The following is a description of a gene set: The process in which the anatomical structures of epithelia are generated and organized. An epithelium consists of closely packed cells arranged in one or more layers, that covers the outer surfaces of the body or lines any internal cavity or tube. species: Mus musculus Mouse Gene Set: GOBP_MORPHOGENESIS_OF_AN_EPITHELIUM, and this is the list of marker genes: Etv5, Astn2, Celsr1, Vegfc, Lef1, Fgf7, Setdb2 (NCBI Gene Id 239122), Cobl, Fgfr3, Foxn1, Acvrl1, Podxl, Flna, Clic4, Tfap2a, Stat5a, Brpf1, Nkd1, Smad4, Lin7c, Gli3, Dlg1, Bcl2, Mir216b, Ripk4, Dlg3, Adamts12, Sox11, Dlc1, Rarg, Epha2, Dll1, Fat1, Maged1 (MAGE family member D1), Eng, Rnf207, Foxa1, Bcl10, Grem1, Fermt2, Erbb4, Hey1, Wdpcp, Bbs4, Wnt2, Cc2d2a (coiled-coil and C2 domain containing 2A), Pax2, Nrarp (NCBI Gene Id 67122), Phldb2, Htt, Irx1, Rxra, Ccn1, Pard3, Brsk2, Fzd3, Pla2g10, Krt6a, Hoxb7, Plxna1, Hs3st3b1, Nfatc4, Rspo2, BC028528, Aldh1a3, Gsdma3, Casr, Igf1, Lbx2, Prkaca, Alx1, Hand2, Tgm2, Ahi1, Arl13b, Timeless, Tcf21, Fermt1, Mmrn2, Cxcl12, Cluap1, Specc1l, Dll4 (NCBI Gene Id 54485), Etv4, Robo1, Wnk4, Krt71, Kras, Cd44, Tbx18, Wnt9b, Pak1, Smarca1 (SWI/SNF related, matrix associated, actin dependent regulator of chromatin, subfamily a, member 1), Cited1, Scnn1g, Tgfb2, Ovol2 (NCBI Gene Id 69059), Wnt3a, Col5a1, Lhx2, Brsk1, Pthlh (parathyroid hormone-like peptide, NCBI Gene Id 19227), Prkacb, Rhoc, Lif, Itgax, Vegfa (NCBI Gene Id 22339), Apaf1, Epha7, Tacstd2, Wt1, Sulf1, Ppp1ca, Ilk, Cdh1, Camsap3, Spint1, Alox12, Clasp1, Sox9, Runx3, Fat4, Commd5, Cd151, Zic2, Fzd5, Hoxa13, Jag1, Pgr, Ctsd, Dnaaf1, Msx2, Ntn1, Ift172, Fgfr2, Mst1, Greb1, Kdm2a, Gzf1, Cthrc1, Tgfbr2, Npnt (nephronectin), Cyp7b1, Rpgrip1l, Arhgap24, Ngfr, Six2, Naglu, Actg1, Gja1, Arhgap35, Fzd6, Krt6b, Pdgfb, Cfl1, Hoxb2, Foxd1, Mgp, Lrg1, Ryr2, Nkx2-5, Ophn1, Crb3, Wdr1, Crygs, Mtor, Grhl2, Foxc2, Tie1, Aldh1a1, T, Gdnf (NCBI Gene Id 14573), Dag1, Krt25, Gli2, Hoxd11, Pml, Lias, Kif3a, Cep290, Foxp1, Kif26b (NCBI Gene Id 286945), Spag6l, Ajap1, Smarca4, Abl2, Csnk2b, Tgfb1, Nup50, Plxnd1, Abl1, Plet1, Itgav, Tbx20, Ccdc39, C2cd3, Foxa2, Kdm5b, Hhex, Hand1, Hoxa5, Pspn, Gpc3, Cxcr2 (C-X-C motif chemokine receptor 2), Nkx2-1, Hoxb4, Zeb2, Pitx2, Ift52, Dvl1, Foxh1, Rbpj, Nherf1, Pdgfra, Scnn1b, Actb, Map3k1, Gbx2, Cfc1, Noto, Ctnnb1, Tctn1, Cited2, Ret, Cdk20, Tgfb1i1, Ctnnbip1, Snai2, Fgf1, Phactr4, Tnf, Ift20, Osr1, Dlx3, Klk14, Csmd1, Bmp4, Trp63, Tcf15, Dchs1, Ski, Grsf1, Shh, Lrp6, Pxn (paxillin), Ccdc40, Rps7, Pkhd1, Dvl2, Wnt5a, Tbx3, Serpinb5, Rreb1, Stard13, Kdf1, Mthfr, Med12, Rab23, Tnc, Atp7a, Gna13, Stox1, Lmo4, Fgf3, Pafah1b1, Gorab, Fuz, Ctnnd1, Hes1, Traf6, Nrp1, Hoxb13, Trim28, Smo, Mycn, Lama1, Wnt11, Myc, Pdcd10, Smad3, Gcm1, Id4, Foxn4 (NCBI Gene Id 243222), Prkx, Aldh1a2, Ptch1, Hmga2, Frem2 (NCBI Gene Id 71477), Fgf8, Cxcr4, Gata3, Deaf1, Acvr1, Sos1, Arid1a, Pbx1, Nfatc3, Ttc8, Casp8, Hhip, Foxq1, Tsc2, Hnf1b, Stat1, Tbx5, Ccm2, Esr1, Hoxa11, Tulp3, Egfr, Plod3, Dicer1, Zic5, Alms1, Fkbpl, Sall1, Ncoa3, Glmn, Tbx1, Gatad2a, Pax3, Mmp2 (matrix metallopeptidase 2), Mef2c, Esrp2, Mmp14, Itgb5 (NCBI Gene Id 16419), Met, Nphp1, Gata4, Wdr83, Tbx4, Bmp7, Rhoa, Sufu, Tmem59l (transmembrane protein 59-like), Hoxd13, Cecr2, Clasp2, Stk4, Slc12a2, Cxcl10, Ift122, Cav3, Col4a1, Tbx2, Nkx3-1, Snai1, Wnt10a, Kat2a, Aplnr, Itga5, Foxf2, Aire, Eya1, Spint2, Sec24b (SEC24 homolog B, COPII coat complex component), Pkd2, Hectd1, Spry1, Sema3a, Pfn1, Zfp568, Rhob, Notch1, Ajuba, Agtr2, Fras1, Mrtfa (myocardin related transcription factor A), Ddr1, Trim71, St14, Nr3c1, Adamts16, Mir217, Mthfd1l, Mical2, Kif20b, Lrp5, Msn, Ppp3r1, Tmem67, Igf1r, Hesx1, Mmp12, Hes5, Krt27, Fgf2, Mtss1, Pdpn, Traf3ip1, Irx2, Gdf2, Runx1, Epha4, Wnt1, Krt28, Mir216a, Cdc42, Mks1, Prickle1, Sirt6, Ift57, Vdr, Mthfd1, Il10, Rdh10, Twist1, Igfbp5, Grhl3, Tmtc3, Flrt3, Mib1, Fgf10, Vcl, Efnb2, Intu, Wnt7a, Arhgap12, Hbegf, Rala, Lrp2, Plxnb2, Sema3c (sema domain, immunoglobulin domain (Ig), short basic domain, secreted, (semaphorin) 3C), Src, Sdc4, Dspp, Sema3e, Mesp1, Mdk, Pgf, Pals1, Exoc5, Ntn4, Sfrp2, Rara, Pdgfa, Nog, Sostdc1, Perp, Sox8, Pcdh8, Bmp2 (bone morphogenetic protein 2), Sfrp1, Flt1, Vangl2, Ceacam1, Dsc1, Myo9a, Lama5, Lgr5, Kdm6a, Sall4, Med1, Angpt1, Krt16, Yap1, Wnt7b, Ext1, Psen1, Shank3, Phb2, Gdf7, Wnt5b, Map3k7, Folr1, Wnt6, Egf, Jhy, Agtr1b, Il6, Bsg, Ccl11, Notch2, Jag2, Enah (NCBI Gene Id 98642), Ihh, Kdm2b, Coq7, Ptk7, Hs3st3a1, Rasip1, Krt12, Sox17, Prox1, Hs2st1, Srf, Foxf1, Csf1, Sh3bp1, Tmem79, Car9, Rock2, Hdac5, Setd2, Nphp3, Chuk, Six4, Tfap2c, Lbx1, Cplane1, Frs2, Lhx1 (NCBI Gene Id 16869), Zdhhc7, Lgr4, Shroom3, Lamc1, Krt17, Tead1, Sema5a, Agt, Fgfr1, Ipmk, Pax8 (NCBI Gene Id 18510), Klf4, Agtr1a, Socs3, Luzp1, Tmeff2, Pdx1, Syne4, Esrp1, Frzb, Tcap, Rab10, Ctsl, Flg2, Btbd7, Brd2, Sfrp5, Sema4c, Pkd1, Ctsh, Megf8, Kdr, Tgif1, Ahr, Greb1l, Six1, Wnt2b, Car2, Sox10, Llgl2, Hif1a, Stk3, Tek, Rbm15, Slit2, Wnt4 (NCBI Gene Id 22417), Tmed2, Irx3, Enpp1, Areg, Grb2, Zic3, Esr2, Spry2, Rspo3, Ctns (cystinosis, nephropathic), Notch4, Vasp, Lcn2, Slc39a12, Hgf, Pten, Tead2, Adm, Ctsz, Ar, Scrib, Nfatc1, Foxe1, Bmp5 (NCBI Gene Id 12160), Lzts2, Dlg5, Stil, Tor1a, Opa1, Nodal, Nckap1, Edn1, Btrc, Sapcd2, Fem1b, Casp3, Carmil2, Ccdc103, Ednra, Klhl3, Rgma, Fmn1, Asb2, Pik3cd, Tsc1, Pcdh15, Epb41l5, Sox2, Fst